Given this list of marker genes SOX9, IGF1R, ZNF22, CDC27, PDIA4, here is a description of the gene set: Early prostate development genes (up-regulated at 6 hr dihydrotestosterone) which are also up-regulated in lower grade vs higher grade locally invasive prostate cancers. Human Gene Set: SCHAEFFER_PROSTATE_DEVELOPMENT_AND_CANCER_BOX3 species: Mus musculus from publication Schaeffer EM, Marchionni L, Huang Z, Simons B, Blackman A, Yu W, Parmigiani G, Berman DM (PMID 18794802) Cancer cells differentiate along specific lineages that largely determine their clinical and biologic behavior. Distinct cancer phenotypes from different cells and organs likely result from unique gene expression repertoires established in the embryo and maintained after malignant transformation. We used comprehensive gene expression analysis to examine this concept in the prostate, an organ with a tractable developmental program and a high propensity for cancer. We focused on gene expression in the murine prostate rudiment at three time points during the first 48 h of exposure to androgen, which initiates proliferation and invasion of prostate epithelial buds into surrounding urogenital sinus mesenchyme. Here, we show that androgen exposure regulates genes previously implicated in prostate carcinogenesis comprising pathways for the phosphatase and tensin homolog (PTEN), fibroblast growth factor (FGF)/mitogen-activated protein kinase (MAPK), and Wnt signaling along with cellular programs regulating such 'hallmarks' of cancer as angiogenesis, apoptosis, migration and proliferation. We found statistically significant evidence for novel androgen-induced gene regulation events that establish and/or maintain prostate cell fate. These include modulation of gene expression through microRNAs, expression of specific transcription factors, and regulation of their predicted targets. By querying public gene expression databases from other tissues, we found that rather than generally characterizing androgen exposure or epithelial budding, the early prostate development program more closely resembles the program for human prostate cancer. Most importantly, early androgen-regulated genes and functional themes associated with prostate development were highly enriched in contrasts between increasingly lethal forms of prostate cancer, confirming a 'reactivation' of embryonic pathways for proliferation and invasion in prostate cancer progression. Among the genes with the most significant links to the development and cancer, we highlight coordinate induction of the transcription factor Sox9 and suppression of the proapoptotic phospholipid-binding protein Annexin A1 that link early prostate development to early prostate carcinogenesis. These results credential early prostate development as a reliable and valid model system for the investigation of genes and pathways that drive prostate cancer.